Given this list of marker genes Stk38l, Mbnl2, Lemd2, Reep6, Dok4, Ccp110 (NCBI Gene Id 233793), Trp53, E2f1, Ddx46, Il21r, Steap2, 5730455P16Rik, Tsc1, Tom1l2, Plekhm2, Bcl9l, Fgf11, Napg, Tnip1, Nol4l, Sh3kbp1, Wipf3, Rgs12, Add1, Eif5a, Gmeb1, Ehmt1, Usf3, Nacc2, Mapre2, 9530068E07Rik, Golga1, Apol8 (NCBI Gene Id 239552), Septin8, Mettl14, Dop1a, Slc36a1, Prokr1, Btbd2, Cep15, Galns, Bcl7b, Ppp6r3, Arrb1, Fam219a, Car7, Rhof, Espn, Snta1, Nr6a1, Zer1, Zfp385b, Csdc2, Itgb4, here is a description of the gene set: studied in species Mus musculus from publication Xie S, Zhou N, Su N, Xiao Z, Wei S, Yang Y, Liu J, Li W, Zhang B (PMID 38577019) Mouse Gene Set: XIE_TRASTUZUMAB_CARDIOTOXICITY_MMU_MIR_664_5P_GENES Abstract: Trastuzumab-induced cardiotoxicity (TIC) is a common and serious disease with abnormal cardiac function. Accumulating evidence has indicated certain non-coding RNAs (ncRNAs), functioning as competing endogenous RNAs (ceRNAs), impacting the progression of cardiovascular diseases. Nonetheless, the specific involvement of ncRNA-mediated ceRNA regulatory mechanisms in TIC remains elusive. The present research aims to comprehensively investigate changes in the expressions of all ncRNA using whole-transcriptome RNA sequencing. The sequencing analysis unveiled significant dysregulation, identifying a total of 43 circular RNAs (circRNAs), 270 long noncoding RNAs (lncRNAs), 12 microRNAs (miRNAs), and 4131 mRNAs in trastuzumab-treated mouse hearts. Subsequently, circRNA-based ceRNA networks consisting of 82 nodes and 91 edges, as well as lncRNA-based ceRNA networks comprising 111 nodes and 112 edges, were constructed. Using the CytoNCA plugin, pivotal genes - miR-31-5p and miR-644-5p - were identified within these networks, exhibiting potential relevance in TIC treatment. Additionally, KEGG and GO analyses were conducted to explore the functional pathways associated with the genes within the ceRNA networks. The outcomes of the predicted ceRNAs and bioinformatics analyses elucidated the plausible involvement of ncRNAs in TIC pathogenesis. This insight contributes to a better understanding of underlying mechanisms and aids in identifying promising targets for effective prevention and treatment strategies.